Given this list of marker genes GNAS, CSH2, ADCYAP1, CSHL1, JAK2 (Janus kinase 2), PTHLH, JAK3, FYN, NPPB, PTPN11, PTH, JAK1, CCK, UCN3, FABP4, CRH, GH1, GHRH, CSH1, UCN, GRIA1, UCN2, LEP, GNRH1, GPHA2, NPPA, GNRH2, GPHB5, GNAO1, VIP, GH2, SOCS2, TYK2, PSMC5, NPPC, here is a description of the gene set: Human Gene Set: GOMF_HORMONE_RECEPTOR_BINDING species: Homo sapiens Binding to a receptor for a hormone.